The following is a description of a gene set: Human Gene Set: GOMF_OXIDOREDUCTASE_ACTIVITY_ACTING_ON_PAIRED_DONORS_WITH_INCORPORATION_OR_REDUCTION_OF_MOLECULAR_OXYGEN_ANOTHER_COMPOUND_AS_ONE_DONOR_AND_INCORPORATION_OF_ONE_ATOM_OF_OXYGEN species: Homo sapiens Catalysis of an oxidation-reduction (redox) reaction in which hydrogen or electrons are transferred from each of two donors, and one atom of oxygen is incorporated into one donor., and this is the list of marker genes: CMAHP, FA2H, FAXDC2, MSMO1, TYR, TYRP1, CH25H, CYP27A1, DEGS2